The following is a description of a gene set: Mouse Gene Set: GERHOLD_RESPONSE_TO_TZD_DN PPAR gamma is an adipocyte-specific nuclear hormone receptor. Agonists of PPAR gamma, such as thiazolidinediones (TZDs), promote adipocyte differentiation and have insulin-sensitizing effects in animals and diabetic patients. Affymetrix oligonucleotide arrays representing genes were employed to profile the gene expression responses of mature 3T3-L1 adipocytes and differentiating preadipocytes to a TZD PPAR gamma agonist in vitro. The expression of genes was significantly up- or down-regulated by more than 1.5-fold during differentiation and/or by treatment with TZD, and these genes were organized into 32 clusters that demonstrated concerted changes in expression of genes controlling cell growth or lipid metabolism. Quantitative PCR was employed to further characterize gene expression and led to the identification of beta-catenin as a new PPAR gamma target gene. Both mRNA and protein levels for beta-catenin were down-regulated in 3T3-L1 adipocytes compared with fibroblasts and were further decreased by treatment of adipocytes with PPAR gamma agonists. Treatment of db/db mice with a PPAR gamma agonist also resulted in reduction of beta-catenin mRNA levels in adipose tissue. These results suggest that beta-catenin plays an important role in the regulation of adipogenesis. Thus, the transcriptional patterns revealed in this study further the understanding of adipogenesis process and the function of PPAR gamma activation. Genes down-regulated in 3T3-L1 cells (fibroblast) induced to differentiate to mature adipocytes and then treated with a TZD derivative AD-5075, a PPARG activator. from publication Gerhold DL, Liu F, Jiang G, Li Z, Xu J, Lu M, Sachs JR, Bagchi A, Fridman A, Holder DJ, Doebber TW, Berger J, Elbrecht A, Moller DE, Zhang BB (PMID 12021175) species: Mus musculus, and this is the list of marker genes: Apoe, Agt, Pmp22, Cryab, Mcl1, Sox4, Cxcl12, Ghr, Pparg, Cfd, Cebpd, Cd81, Mnt